The following is a description of a gene set: In this study, we have investigated the effect of BLIMP1α on gene expression, cell differentiation and pathogenesis in normal human GC B cells using a non-viral vector based system Genes down-regulated in germinal center B lymphocytes: control versus over-expressing Epstein-Barr virus protein LMP1. studied in species Homo sapiens from publication Vrzalikova K, Vockerodt M, Leonard S, Bell A, Wei W, Schrader A, Wright KL, Kube D, Rowe M, Woodman CB, Murray PG (PMID 21411757) Human Gene Set: GSE27670_CTRL_VS_LMP1_TRANSDUCED_GC_BCELL_DN, and this is the list of marker genes: MAFB, SKI, CRP, ERCC1, RIT2, TFRC, SERAC1, MTHFR, C11orf54, MRAP, RING1, C2, LMO7, SEPTIN9, NNT, ACOX1, SEC61A2, KANSL2, RETREG2, FKBP7, CACHD1, TLR7, LPIN1, TWIST2, RBX1, SNX9, CCDC93, C16orf74, MAP1B, POU2F2, INPP4A, PHPT1, TSPAN4, PCSK7, FBXW4, SYT3, ENTPD6, CLEC4D, PARP2, ATP6AP1, ACYP2 (NCBI Gene Id 98), ZNF22, CRYL1, SLC11A1, PLXNB2, NTPCR, TRAPPC10, ETHE1, RAB34, ADCY3, ADGRG3 (adhesion G protein-coupled receptor G3), CD4, ATP13A2, DSP, XDH, CLCA1, SLC25A36, LRP1, SFXN2, IFT81, RALGDS, PLD3, ANK1, FBXO15, TLR6, KCNJ4, SIRPA, CD300C, TEX2, CERK, CPOX, CDK16, TBC1D24, RAC2, RGL1, MPP1, PLTP, UNC93B1, TPMT, GSTM3, SERPINB6, ST6GALNAC6, STK11IP, LRPPRC, ITGB5, MR1, EPHA4, GAB1, PXK, PDE4DIP, APOE, IFI27, HADH, FOXO3, ARHGAP39, HGSNAT, RAB3IL1, PEX5, HMBOX1, C3, FLCN, AMY2A, OSBPL5, SURF2, HES1, COL6A3, C1QC, ERBB3, COL6A1, ALAS1, ETFBKMT, NAA80, NPPA (NCBI Gene Id 90230), HMGCS2, NR1H2, CIB2, USP2, CD5L, DPH5, HMOX1, CTNNAL1, ZXDB, ARHGEF3, ECI2 (NCBI Gene Id 134779), CMA1, SYNGR1, SLC7A7, ABCC9, P2RX4, RTL6, LAMC1, SLC22A17, ABL1, MED22, DHRS3, TBXAS1, ST6GALNAC2, ADGRE1, SNTA1, CTSV, RHD, NRP1, HOXC6, TEKT2, SHROOM3, GDF15 (growth differentiation factor 15), XPOT, GATA2, FABP4, PLPP3, LRP6, SPIC, IL10, DLL1 (delta like canonical Notch ligand 1), NAV2, MYOZ1, FKBP9, ECHS1, MCAM, THRA, PLD1, KDM3A, CMBL, MYC, CRIP2 (NCBI Gene Id 8112), TFCP2, MEIS1, FICD, LPP-AS2, DEDD, HDLBP, SNAP91, SPNS1, GBF1, ACOT2, SPARCL1, CTSB, HPCAL1, COL11A2, TPRA1, LPP, LGMN, CLPX, AMACR, EPN1, CTSF, CTTN, CBR1, TNS2, SPATS2, MBD6, EPHX1, ZFP90, GGCX, ACP2, PDGFRB, RHOB, CSF3R, TIMP3, HS1BP3